The following is a description of a gene set: Genes predicted to be targets of miRBase v22 microRNA hsa-miR-3677-3p in miRDB v6.0 with MirTarget v4 prediction scores > 80 (high confidence targets). Human Gene Set: MIR3677_3P studied in species Homo sapiens from publication Chen Y, Wang X (PMID 31504780), and this is the list of marker genes: MS4A2, SF3B6, HAS3, VGLL2, HAUS6